The following is a description of a gene set: from publication Chen Y, Wang X (PMID 31504780) Mouse Gene Set: MIR_1943_5P Genes predicted to be targets of miRBase v22 microRNA mmu_miR_1943_5p in miRDB v6.0 with MirTarget v4 prediction scores > 80 (high confidence targets). studied in species Mus musculus, and this is the list of marker genes: Slc7a8, Lpar2, Rin1 (Ras and Rab interactor 1), Eya3, Dnal1, Ap1s3, Psd4, Drc7, Kics2, Zfp59, Prcp, Aif1l, Sema6a, Lrrc59, Slc16a14, Smarcc1, Klhl9, Ttc28 (tetratricopeptide repeat domain 28), Galnt17, Pakap (paralemmin A kinase anchor protein), Mylk4, Klhl4, Gpr173, Nos2, Aoc3, Acad9, Aspg, Kcne1, Mpig6b, Ulk1, C2cd2l, Cts8, Ube2h, Tmem175, Slc7a1, Trp53inp2, Rassf2, Smap2, Shisa7, Ap1g1, Ephb1, Htt, Ankrd63, Chd3, Pkd1, Chst2, Itga8, Rab11fip5, Prdm2, Ptpn3 (protein tyrosine phosphatase, non-receptor type 3), Sf3b4, Bahd1, Zfp92, Gramd2a, Gnat1, Rnd1, Wdtc1, Tfap2a, Nectin1, AU018091, Zfp444, Ccdc171, Msl1, Dop1a, Mtcl2, Rpl31, Samhd1, Nes, Xylb, Klc2, Kcnj10, Erv3, Cyyr1, Selenom, Klk4, Pak1ip1, Dmtn, Eif4e1b, Idi2, Pianp, Ubqln2, Matcap1, Dlk1, Slc1a3, Avpr2, Rnf150, Ap2a1, Arnt2 (NCBI Gene Id 11864), Slc8a2, Wnt1, Uqcrq, Tlcd5, Ranbp10, Ipmk, St3gal1, Bhlhe40, Zmat3, Rftn2, Rnf152, Zfp395, Fosl2, Bzw1, Tspan9, Ctnnd1, Lhpp, Fign, Lrrtm1, Trim58, Plxna4, Hoxc10, Sash1, Leng8, Morc4 (microrchidia 4), Baz2a, Arhgdia, Mon1b, Mospd3, Emc4, Dhtkd1, Astn2, Mea1, Mxd4, Zfhx3, Bard1, Clec16a, AI837181